Given this list of marker genes Tlr7, Gpr119, Wwtr1, Zc3h12c, Cdc7, Sucla2, Ect2, Phf20l1, Celf2, Wls, Rnf20 (NCBI Gene Id 97155), Mllt6, Dnajc25, Ugt8a, Prrc2c, Napepld (NCBI Gene Id 242864), G6pc1, Rfx7, Thoc1, 2700097O09Rik, Atf1, Prr5l, Slc35f1, Setd2, Gm15107, Grik2, Mapk1, Syt1 (synaptotagmin I), Ephb1, Otud4, Ahcyl1, Fam13c, Snx25, Mfsd9 (NCBI Gene Id 211798), Igdcc4, Rragd, Rasl11b, Ube3a, Rgs17, Plcxd2, Hoxa3, Fn1 (fibronectin 1), Chmp5 (NCBI Gene Id 76959), Il21, Zmynd8, Nat2, Tmcc3, Gm3636, here is a description of the gene set: species: Mus musculus from publication Chen Y, Wang X (PMID 31504780) Mouse Gene Set: MIR_184_5P Genes predicted to be targets of miRBase v22 microRNA mmu_miR_184_5p in miRDB v6.0 with MirTarget v4 prediction scores > 80 (high confidence targets).